Given this list of marker genes GLRA1, BEST1, TTYH2, GLRA3, GLRB, ANO2 (anoctamin 2), TTYH1 (NCBI Gene Id 57348), GABRA3, GABRR3, GLRA2, GABRA4, ANO10, BEST2, ANO3, CLCA1, GABRB1, GABRA5, GABRB2, P2RX5, ANO6 (anoctamin 6), GABRQ, CLCA4, GABRA6, SLC1A7, ANO5, BEST4, TTYH3, GABRA2 (NCBI Gene Id 2555), BEST3, GABRR2, ANO9, GABRG2, GABRE, CLCA2, PACC1, GABRA1 (NCBI Gene Id 2554), NMUR2, GABRB3, AQP6, SLC17A7, GABRG1, ANO4, GABRP, ANO8 (anoctamin 8), GABRR1, CFTR, GABRG3, ANO7, ANO1, here is a description of the gene set: species: Homo sapiens Human Gene Set: GOMF_LIGAND_GATED_MONOATOMIC_ANION_CHANNEL_ACTIVITY Enables the transmembrane transfer of an inorganic anion by a channel that opens when a specific ligand has been bound by the channel complex or one of its constituent parts.